The following is a description of a gene set: Mouse Gene Set: GOBP_LATE_ENDOSOME_TO_LYSOSOME_TRANSPORT The directed movement of substances from late endosome to lysosome. species: Mus musculus, and this is the list of marker genes: C9orf72, Chmp6, Snapin, Arl8b, Plekhm1, Chmp5, Chmp7, Plekhm2, Vps4b, Vps4a, Chmp2b, Chmp1b2, Vps41 (VPS41 HOPS complex subunit), Chmp3, Vps39, Chmp4c, Chmp1a, Arf1, Chmp2a, Chmp1b, Chmp4b, Vps35